The following is a description of a gene set: DNA copy number amplifications activate oncogenes and are hallmarks of nearly all advanced tumors. Amplified genes represent attractive targets for therapy, diagnostics and prognostics. To investigate DNA amplifications in different neoplasms, we performed a bibliomics survey using 838 published chromosomal comparative genomic hybridization studies and collected amplification data at chromosome band resolution from more than 4500 cases. Amplification profiles were determined for 73 distinct neoplasms. Neoplasms were clustered according to the amplification profiles, and frequently amplified chromosomal loci (amplification hot spots) were identified using computational modeling. To investigate the site specificity and mechanisms of gene amplifications, colocalization of amplification hot spots, cancer genes, fragile sites, virus integration sites and gene size cohorts were tested in a statistical framework. Amplification-based clustering demonstrated that cancers with similar etiology, cell-of-origin or topographical location have a tendency to obtain convergent amplification profiles. The identified amplification hot spots were colocalized with the known fragile sites, cancer genes and virus integration sites, but global statistical significance could not be ascertained. Large genes were significantly overrepresented on the fragile sites and the reported amplification hot spots. These findings indicate that amplifications are selected in the cancer tissue environment according to the qualitative traits and localization of cancer genes. studied in species Homo sapiens from publication Myllykangas S, Himberg J, Böhling T, Nagy B, Hollmén J, Knuutila S (PMID 16751803) Human Gene Set: MYLLYKANGAS_AMPLIFICATION_HOT_SPOT_23 Amplification hot spot 23: colocolized fragile sites and cancer genes in the 11q12-q25 region., and this is the list of marker genes: DDX10, KMT2A, FLI1, NUMA1, MAML2, POU2AF1, CCND1, PCSK7, CLP1 (cleavage factor polyribonucleotide kinase subunit 1), CBL, ARHGEF12, SDHD, PAFAH1B2, PICALM (phosphatidylinositol binding clathrin assembly protein), ZBTB16, ATM (ATM serine/threonine kinase), DDX6, BIRC3, MEN1